Given this list of marker genes LRRC32, MAK, TNFRSF13B, VIPR1, PTGIR, PPARA, GRN, SCNN1A, ITGAL, FXYD1, PENK, EFNB1, GRPR, C3, CDKN1A, FCGRT, LAG3, IL1R1, LILRB2, LDLR, GP1BB, CNR1, FGF7, SLC4A1, LILRA2, CCL19, PTPRN, ENPEP, CAMK4, GJA1, CD14, CCL4, IL15RA, CX3CL1, IL7R, RORA, ADAM9, ABCA1, ITGA3, KLRC1, PRKD1, ASGR1, GRIK1, ICAM1, AQP7, PTPRD, HTR2B, GPRC5A, SLC1A6, HLA-DRA, HLA-A, NPR3, CD37, HTR4, AKAP12, LTB, LPAR1, SLC6A3, PFKFB3, TGFA, HPS1 (HPS1 biogenesis of lysosomal organelles complex 3 subunit 1), ADGRE1, XCL1, RGS2, RHBDL1, PFKFB4, EDNRB, CXCL1, KCNJ2, NRG1, GUCY2F, S100A6, TIRAP, FGR, IL6ST, GAST, IL18R1, FCER1A, VAMP1, DUSP6, CLCNKA (chloride voltage-gated channel Ka), NTSR2, MUSK, IFNG, CNTFR, CCL2, LILRA1, FCGR3A (NCBI Gene Id 2214), GLRA1, AVPR1B, RRH, SLC22A4, TNFRSF21, MAPK4, GABRP, CD4, CHRNA7, AQP3, PDK4, SLC17A3, DAPK1, S100A9, ASIC2, CXCR6 (NCBI Gene Id 10663), PPBP, ICAM4, CRLF1, FCGR1A, CSF2RA, PRB4, FGFR1, EFNA5, NAMPT, CNTN2, TACR3, CXCL2, TRPM2, HLA-DOA, SLC15A2, KIR2DL4, TSPAN4, CCL7, IL27RA, MYLK, CCL13, MMP14, IL1B, CCL20, PRPH2, FADS2, KCNH2, KIT, CD82, GABRR1, GPA33, CCR8, TNC, HLA-DMB, KCNK3, RGS4, SLC18A3, APOB, GHR, CXCL9, SLC34A1, CD83, TPO, HTR3A, PIGR, CSH2, ACKR2, ECM2, CXCL11, SLC13A2, CD163, KCNK1, KCNJ4, CD86, CD3E (NCBI Gene Id 916), CNR2, CSF3, IL15, SLAMF1, HLA-C, CNTNAP1, NCKAP1L, PRKCH, SCN7A, PF4, IL17A, GRK5, IL4R, AREG, MCAM, FGFR2, IGF2, CD8A, CSF2RB, ADAMDEC1, EPHA7, LAT, CCL14, MAP3K8, MLANA, CHRNA2, CHRNA4, BDKRB2, CILP, P2RY14, JAG1, CD2, GP9, GPR3, KCNN1, NEO1, DDR2, LTA, CCR9, GRB14, SLC18A2, CD63, ADRA2A, SLC22A6, OSM, SLC10A1, IL1A, CXCL14, FCGR2A, SSTR2, WNT2, SLC6A11, PTPRC, FXYD2, HK3, TLR3, SLC16A4, EPHB1, MST1R, CCL17, THBD, PTAFR, TNFSF14, HAS2, GPLD1, GYPC, FOLR3 (folate receptor gamma), HLA-DRB5, NPY1R, ACKR1, TLR1, STAT1, B2M (NCBI Gene Id 567), CEACAM4, HPN, NRP1, LEPR, CALCRL, F3, PTPRE (NCBI Gene Id 5791), FXYD3, GLRA2, TSPAN7, PROM1, CEACAM1, CLDN4, OLR1, CD22, CACNG1 (NCBI Gene Id 786), KCNJ6, IGSF6, LIF, EPOR, HTR7, AGTR1, FOLR2, CLDN1, CD3D, GPR65, ASGR2, SLA, SLC16A2, ITGAX, CXCL12, CD69, TNFRSF10C, P2RX1, CCN3, IL11, SLC4A3, AGT, RNASEL, CXCR5, IL3RA, FRZB, CD6, CXCL13 (C-X-C motif chemokine ligand 13), ART3, CD1C, PDGFRA, CRHR2, SLC16A3, C3AR1, FCER2, LY6E, AQP9, ICAM3, PDPN, P2RX7, KCND3, HBEGF, KCNN4, RYR1, MEP1A, KIR3DL1, FPR1, PGLYRP1, CXCL8, KCNC3, NTS, GPRC5B (G protein-coupled receptor class C group 5 member B), FLT1, BPI, NGFR, NR4A2, IL6, CCKBR, GLYAT, ADORA1 (adenosine A1 receptor), CGA, PDYN, CR2, MS4A2, PTPRO, PTPRH, PTPRR, FLT3, ROR2, RGS16, CD300C, GRM2, AXL, TACSTD2, HAS3, RAMP3, ITGA10, EFNA3, LSP1, EPHA4, GYPB, PTPRM, ADM, IL2RB, GNA15, GABRG3, RGS5, CD79A, CD53 (NCBI Gene Id 963), ATP4A, CCKAR, LGALS3BP, GNG11, PTH2R, EDN3, LPAR6, STAT4, IL24, S1PR4 (sphingosine-1-phosphate receptor 4), IFITM1, TNFSF4, PLAUR, AQP1, TEK, AQP8, CD55, TNFSF10, EPHA2, FPR2, CD9, RXRA, TLR2, DRD3, AVPR1A, SLC6A4 (solute carrier family 6 member 4), CAV1, ITGB2, OXTR, CD5L, ITGB7, AQP5, DUSP5, ANXA1, IL1RAP, CFI, UNC13B, ANPEP, GYPE, GABRB3, EVI2A, FGF6, SELL, HCAR3, SLC12A3, CHRND, CD79B, CHRNB1, HTR2A, CHRNB4, SLC6A2, APOE, ITGAM, FAT1, STAT2, TM4SF5, TSPAN8, MRC1, CHRNB3, EPHB6, SPN, PTH1R, DYRK3, CCR2, NKG7, NR0B2, CCR1, ITGB5, CLDN10, PRKCQ, NGF, ROR1 (NCBI Gene Id 4919), CCL3, LANCL1, AHR, FCER1G, MPZL1, IL2RG, IL9, LAPTM5, IFNGR1, GALR3, CD5, RHAG, GP5, CX3CR1, RGS13, GPR39, CXCL10, TNFRSF11B, IL10RA, EDNRA, PLPP2, OXT, NTRK1, CCL21, PDGFB, SFRP4, PRSS12, CCL1, CD8B, PTPRS, STC1, OGN, CD247, FOLR1, FASLG, SLC4A4, JAM2, SCGB1A1, GHRHR, ATP7B, CD19, IGF1, MAL, LILRB3, CSF3R, CD40, CCL18, EREG, ADRA2B, CCR5, KLRK1, GFRA3, PFKFB1, IL13RA2, SLC29A2, GPM6A, C9, LCK, PYY, CD3G, P2RY10, SKAP1, CD96, ART1, PDGFRL, CCL23, SEMA4D, OPRK1, AGRP, APOH, BMP2, GPR182, CCK, C5AR1, ADRB2, SLC6A7, INHBA, DUSP2, STOM, CDK5R1, TNFRSF1B, TNFRSF25, SLC6A1, LGALS3, TNFSF12, MUC1 (NCBI Gene Id 4582), CXCR4, ITGA2B, IRAG2, MS4A1, NPY, BST2, CSF1, RARB, CLEC2B, CCL11, GPR183, CHRNE, EFNA4, CCL8, IL6R, HTR6, TYROBP, SH2D1A, FAS, GABRE, KCNQ3, TMPRSS2, here is a description of the gene set: studied in species Homo sapiens Membranal receptors. Human Gene Set: MODULE_64